Given this list of marker genes Mpzl2, Slc41a2, Trim12a, Bpgm, Cited1, Amacr, Cavin3, Fgg (fibrinogen gamma chain), Stc2, Sorl1 (NCBI Gene Id 72910, sortilin-related receptor, LDLR class A repeats-containing), Chrdl1 (chordin-like 1), Vamp3, Galc, Tmem45b, Gsta3 (NCBI Gene Id 14859), Trim34a, Zfp386, Phgdh, Bid, here is a description of the gene set: Mouse Gene Set: HOWLIN_CITED1_TARGETS_2_DN Expression microarray analysis identified CITED1 among a group of genes specifically upregulated in the pubertal mouse mammary gland. At puberty, CITED1 localizes to the luminal epithelial cell population of the mammary ducts and the body cells of the terminal end buds. Generation of CITED1 gene knockout mice showed that homozygous null mutants exhibit retarded mammary ductal growth at puberty and, in addition, dilated ductal structures with a lack of spatial restriction of the subtending branches. Analysis of CITED1 homozygous null and heterozygous null mammary gland gene expression using microarrays suggested that the mammary-specific phenotype seen in the homozygous null females is due to a disturbance in the transcription of a number of key mediators of pubertal ductal morphogenesis. These include estrogen and TGFbeta responsive genes, such as the EGFR/ErbB2 ligand, amphiregulin, whose transcription we suggest is directly or indirectly regulated by CITED1. from publication Howlin J, McBryan J, Napoletano S, Lambe T, McArdle E, Shioda T, Martin F (PMID 16278680) Genes down-regulated in mammary glands from the CITED1 knockout mice: homozygotic vs wild type (WT) animals. species: Mus musculus